Given this list of marker genes HNRNPH1, NFE2L2, BCAR3, NFKBIA, COL7A1, KLRC2, NR4A1, RAB1A (NCBI Gene Id 5861), CCND1, FUBP1, PLK2, SRSF5, SRSF1, JUNB, TXNRD1, KRT19, CYTH1, ELL2, SDCBP, EGR3, EPHA2, SNAI2, IER3, CD83, SGK1, TNFRSF12A, IL6, MAP2K3, EFNA1, SERPINB5, KRT14, EWSR1, TRAF4, MFAP2, SYNCRIP, CCN1, FHL2, MCL1, CCNK, here is a description of the gene set: from publication Dorn A, Zhao H, Granberg F, Hösel M, Webb D, Svensson C, Pettersson U, Doerfler W (PMID 15681441) Genes down-regulated in HeLa cells (cervical carcinoma) 48 h after infection with adenovirus Ad12. The infection of human cells by adenoviruses leads to a gradual reduction in the activity of host cell functions while viral gene expression progresses in a regulated way. We used the DNA microarray technique to determine the transcriptional activity profiles of cellular genes upon infection with adenovirus type 12 (Ad12). The microarray data were validated by quantitative real-time PCR for genes which showed significant alterations after Ad12 infection. At 12 h postinfection, there is a striking up-regulation between 10- and 30-fold in the expression of the G1P2, IFIT1, and IFIT2 cellular immune response genes compared to mock-infected cells. At later stages of infection, when the majority of regulated cellular genes has been turned down, a limited number of cellular genes exhibit increased activities by factors of 3 or less. These genes belong to the signal transduction or transcriptional regulator classes or are active in protein degradation, like ANPEP, an aminopeptidase. The SCD and CYP2S1 genes function in lipid metabolism. The eucaryotic translation initiation factor 4 is up-regulated, and one of the major histocompatibility complex genes is diminished in activity. For two of the genes, one up-regulated (CTSF gene) and one down-regulated (CYR61 gene), alterations in gene activity were confirmed at the protein level by Western blotting experiments. Increased genetic activity of cellular genes late in adenovirus infection has not been reported previously and demonstrates that Ad12 has a sustained control of host cell gene expression well into the late phase of infection. Human Gene Set: DORN_ADENOVIRUS_INFECTION_48HR_DN studied in species Homo sapiens